Given this list of marker genes CYP24A1, here is a description of the gene set: Reactome Pathway: Defective CYP24A1 causes HCAI Catabolic inactivation of the active, hormonal form of vitamin D3 (calcitriol, CALTOL, 1,25-dihydroxyvitamin D3) is initially carried out by 24-hydroxylation, mediated by 1,25-dihydroxyvitamin D3 24-hydroxylase (CYP24A1). The product formed is eventually transformed to calcitroic acid, the major water-soluble metabolite that can be excreted in bile. Defects in CYP24A1 can cause hypercalcemia infantile (HCAI; MIM:143880), a disorder characterised by abnormally high level of calcium in the blood, failure to thrive, vomiting, dehydration, and nephrocalcinosis. part of: Metabolic disorders of biological oxidation enzymes species: Homo sapiens